Given this list of marker genes Vapb, Vapa, Ccl8, Smc6, Zc3h12a, Eif2ak4, Prkn, Smc5, Ccnk, here is a description of the gene set: A process in which a host organism stops, prevents or reduces the frequency, rate or extent of viral genome replication. species: Mus musculus Mouse Gene Set: GOBP_NEGATIVE_REGULATION_BY_HOST_OF_VIRAL_GENOME_REPLICATION